Given this list of marker genes DEFB108B, ITPR3, UNC13D, RNASE3, H2BC17, ATP6V1B1, ATP6V0A1, CCT2, IGLV3-19, C1QA, CANT1, DOK3, SURF4, IGKV2-29, IRAK2, HEXB, SELL, ACTR2, CAPZA1, IGF2R, FOS, PRKCD, NHLRC3, PAK1, IRF3 (NCBI Gene Id 3661), SNAP29, LRRC14, TRIM25, LEAP2 (liver enriched antimicrobial peptide 2), CASP10 (caspase 10), IGKV2D-40, IGLV4-69, APEH, CLEC4A, GPR84, RAB3D, CST3, PLD3, HRNR, BTRC, PRG2, CALM3, TLR10, KIR2DS5, NCSTN, SPTAN1, S100A1, LAT, CFHR5, KRAS, CRK, CD177, USP18, ARHGAP9 (NCBI Gene Id 84526), DEFB125 (defensin beta 125), TEC, PSMA3, PRKDC, NFKBIA, ADAM8, IGHG1, BIRC2, RNF135, ADGRG3, ATP7A, CFHR1, GOLGA7, MIF, PIK3C3, DNAJC3, MAPK11, DSG1, ATP6V1B2 (NCBI Gene Id 526), MMP8, PRKCE, CHRNB4, ATP8B4, DEFB133, CLEC5A, F12, HSPA1B, FGL2, DEFB129, C5AR2, EPX, RAB31, CDA, MALT1, ARL8A, RAB18, AGPAT2, NLRC4, CYBA, KLRK1, IRAK1, MUC12, CFH, IFI16, TARM1, IGLC2, CD53, NOD2, ITLN1, DOCK2, FGB, IGHG4, VCL, FUCA1, LIMK1, IRAK4, PTPN4, IGKV3D-20, ARSA, SRP14, GNS, CD19, COMMD9, TNFAIP3, PSMB5, MUC16, PFKL, H2BC12, PDXK, DEFB112, DOCK1, PSMD2, SERPINB3, MYH9, IGLV2-14 (immunoglobulin lambda variable 2-14), TYROBP, SYNGR1, HRAS, DEFB123, ospC3, MYO5A, NOS1, ITGAV, DEFB1, TMEM63A, FCN3 (ficolin 3), RAB5C, MMP9, NOD1, RHOG, PLD2, RAB6A, IFNA1, DEGS1, DHX58, RIGI, DEFB130A, ATP6V0A2, DIAPH1, PPP2CB, SIGLEC16, UBE2L6, IGLC6, S100A8 (NCBI Gene Id 6279), IDH1, HSP70, MYO10, MASP2, TMC6, WIPF3, MAP3K7, PSMD11, ASAH1, CASP3, IGLC7, H2BC4, C6orf120, H2AC18, AZU1, DEFB108A, EPPIN (NCBI Gene Id 57155), POLR3H, TLR3, LTA4H, SLC2A5, NLRP3, H2BC3, ITGB2, MNDA (myeloid cell nuclear differentiation antigen), CSTB, SERPINB12 (NCBI Gene Id 89777), KNG1, IFNA16 (NCBI Gene Id 3449), TKFC, SSA2, YPEL5, PIGR, AHSG, PSMA7 (proteasome 20S subunit alpha 7), QPCT, VCP (valosin containing protein), IMPDH1, PRKCSH, BPIFB4, ERP44, UNC93B1, VAV3, C9 (complement component 9), PPP2R1B, H2AC6, CCT8, SHC1, MAN2B1, PPP3R1, CTSH, ITPR1, GM2A, LAMP1, POLR3B, IKBKE, CARD11, POLR3K, CD81, TRIM4, FCER1A, ABI1, CTSL, IGKV1D-12, IGLV, TNIP2, MYO1C, GRN, ENPP4, IGHV2-5, NCKIPSD, CASP8, S100A9, IGHV3-33, AGER, SERPINA3, NFAM1, DEFB128, IGLV2-11, IGLV3-1, CASP1, DEFB4A, LPCAT1, FADD, DEFB114, CAB39, OSTF1, DEFB121, CARD9 (caspase recruitment domain family member 9), PSAP, NBEAL2, ARPC4, IGHV4-59, COTL1, HSP90AB1, ILF2, TRAF2, HMGB1, MYD88, H3C15, XRCC5, SLPI, KLRC2, MAPK10, REG3G, DNM3, TLR5, IKBKG, MAPK3, TXN, SOCS1, 1C, IGHV3-9, CD59, TAB1, MEF2A, S100A7, CD180, CLEC4E, IGLV5-45, PADI2, PGM2, NPC2, RIPK1, COPB1, PSMD3, HK3 (NCBI Gene Id 3101), TAB2, IRF7 (NCBI Gene Id 3665), SYK, CTNNB1, NIT2, hly, ATP6V1G3, IGLV8-61, RAC1, DEFB103A, PGLYRP3, CFHR2, CALM1, NCF1, C8B, DEFB110, DHX9, MAVS, IGHV1-46, TOLLIP, TXNDC5, ARHGAP45, SERPINB10, CRISPLD2, porB, CFHR3, TBC1D10C, DEFB109B, N4BP1, PTPRN2, IGKV1-12, DEFA5 (NCBI Gene Id 1670), HLA-C, IMPDH2, IGKV2-30, MEF2C, RAB10, MME, VAPA, MANBA, ALOX5, STOM, IGHE, RIPK3, CCL22, RAB4B, PSMC6, IGKV1-33, VNN1, DEFA4, IFNA10, CD4, TXK, POLR3G, IFIH1, LRRFIP1, ANO6, HLA-H (major histocompatibility complex, class I, H (pseudogene)), SERPINB6, ARPC2, WASL, TMEM179B, CYFIP1, ATAD3B, BIRC3, B2M, TP53, IGHV3-53 (immunoglobulin heavy variable 3-53), SIGLEC9, RAB24, MEFV, TLR9, ARSB, MAP2K1, KIR2DS2, RASGRP4, CMTM6, NCF4, CLEC12A, S100P, CRCP, ATP6V1G1, F2, LCP2, MAPK1 (NCBI Gene Id 5594), MAPK7, VAV2, RBSN, SLC44A2, RAB7A, RELB, H2AZ1, FGG, TOMM70, PSMD8, CFD, H2BC5, SLC15A4, IGHV2-70, CD36, CHUK, ITGAM, KCMF1, PSEN1, IFNA8, HSPA1A, ATP6V1E2, PSMB6, IGLV2-8, C1S, USP14, SARS coronavirus, complete genome, CTSS, CTSC, NCR2, CFHR4, CEACAM3, ACP3, PRDX4, CXCR1, MASP1, ATP6V0D2, UBA3, PTAFR, IGKV1-16, MUCL1, CRACR2A, PSMA4, TXNIP, UBE2D1, UBR4, HBB, PSMA6, SIGLEC5, WASF1, IGLV1-51, PELI2, BCL2L1, ISG15, POLR3GL, ALAD, RNASET2, AHCYL1, LTF, LAT2, C4B, IFNA5, MUC6 (mucin 6, oligomeric mucus/gel-forming), KCNAB2, WAS, ORMDL3, ARPC1A (actin related protein 2/3 complex subunit 1A), RPS6KA2, SIGLEC15, CTSZ, 7a, IGLV2-23, KIR2DS4, MUC3A (mucin 3A, cell surface associated), PDPK1, MAP3K8, FLG2, CLEC6A, MS4A3, NLRP4, TRAPPC1 (trafficking protein particle complex subunit 1), LCN2, H4C1, WASF2, C5, ATP6V0D1, ADA2, FCER1G, CKAP4, BST1, IGLV5-37, NFKB1, TOM1, IGKV1D-16, PGLYRP1, H2BC14, IGLV3-25, SFTPA1, IGLV7-46, CASP2, VAV1, PSTPIP1, PIK3R4, YES1, CYB5R3, DSC1, SERPINB1, SLC11A1, UBE2K, LGMN, PIK3R1, UBE2V1, CCL17, TBK1, LRG1, IRF5, PECAM1, IKBIP, RAP1B, H2AB1, CAPZA2, ACTG1, ELK1, GYG1, RNASE6, SCAMP1, MPO, CTSB, HGSNAT, DEFB127, EEA1, C3, UBE2D3, POLR2L, H2BC21, SEM1 (NCBI Gene Id 7979), CEACAM8, BPI, CD58, TLR7, PSMA5, ATP8A1, DEFB135, APOB, GSDMD, RNASE2, RIPK2, POLR2F, ELMO2, TMT1A, DEFB116, RPS6KA1, SNAP25, C2, IGKV3-20, ATP6V0C, ALDH3B1, DGAT1, MAPK12, S, C7, UBE2D2, MUC3B, PKP1, FBXW11, LYZ, ITGAL, P2RX1, PLEKHO2, ATP6AP2, ATP6V1D, CD247, ACTR3, IGKV3-15, ABCA13, DDX41, COLEC11, ARG1, TRIM32, FCGR3B, NFKB2, TLR2, DNAJC13, PRSS3, IGKV1D-39, RPS6KA3 (NCBI Gene Id 6197), PPBP, CSNK2B, ATP6V1H, CLU, ACTR1B, LGALS3 (galectin 3), AIM2, DEFA6, DPP7, FCGR3A, MAP2K7, PSMC2, FYN, PSMC5, CASP9, FUCA2, DEFB104A, DEFA1 (NCBI Gene Id 504182), DEFB115, GBP4, NEU1, CD55, BIN2, IGHV4-34, IGHV1-69, GALNS, GRAP2, FGR, PANX1, AGL, IFNA14, GPI, PKM, PYGL, DNAJC5, CYLD, CPB2, RAB27A (RAB27A, member RAS oncogene family, NCBI Gene Id 5873), CCR2, C4A, C3AR1, ATG5, NFATC3, TMEM30A, IFNB1, KRT1, C1QB, DEFB134, PAK3, FRK (NCBI Gene Id 5752), FCGR1A, PYCARD, STK11IP, CLEC4C, DEFB124, CTSD, PSMD14, TIFA, CFP, TCIRG1, DHX36, WASF3, MYO9B, NLRC5, POLR3C (NCBI Gene Id 10623), OLFM4, CALM2, DYNLL1, HSPA6, APAF1, IGHG3, LAMTOR2, ICAM3, TSPAN14, CLEC10A, FRMPD3, SRC, NOS3, MAGT1, SARM1, DYNLT1, TLR1, CHI3L1, CTSG (cathepsin G), AOC1, ITK, CASP4, ITCH, GSN, DNASE1L1, AP1M1, IGKV4-1, BCL2, FPR2, CCR6, H2BC13, CDK13, PSMB4, CHGA, CEACAM1 (NCBI Gene Id 634), MLEC, SAA1, ATOX1, PTPRB, PSMD13, LAMTOR3, CRISP3, NCF2, CRP, HCK, IGLV4-60, FABP5, HSP90B1, CUL1, MAPK13, H2AC14, H2BC1, MUC19, CD93, NFATC1, 9b, TLR4, DTX4, GAB2, CAT, RAB44, PPP2R5D, MS4A2, POLR1C, BCL10, N, GBP2, PGLYRP2, REG3A, LY96, DEFB106A, fljB, DSP, IGKV1D-33, PI3 (peptidase inhibitor 3), IRAG2, PSMD7 (proteasome 26S subunit, non-ATPase 7), PA2G4, PPP2CA, MMTAG2, IGLV7-43, MUC20, PGM1, 3a, TIMP2, SERPING1, TRPM2, IGHG2, ZBP1 (NCBI Gene Id 81030), IFNA4, RPS6KA5, IGKV1-17, NFKBIB, RNF125, PELI1, ELMO1, SLC2A3, ARPC3, PRG3, IGLV1-47, CALML5, IGKV2D-30, ATP6V0B, SLC27A2, DUSP7, FOLR3, SNAP23, RAP2B, HRG, IGLV4-3, C8G, PLCG1, PLAUR, ADAM10, OTUD5, MYH2, CR1, POLR2H, PLAC8, PNP, TREX1, VAT1, RAP1A, APRT, TICAM2, UBA7, KIR2DS1, BPIFB1, CPNE3, ATP6V1A (NCBI Gene Id 523), MAP2K6, LCK, ITGAX, CD209, IGLV3-16, RASGRP2, H2AX, IST1, PLPP4, IGLV6-57, CYSTM1, PRTN3, WIPF1, DUSP4, CEP290, MAPK9, CD300LB, CPPED1, GZMM, LAIR1, HTN1, ATP6V1G2, PGRMC1, PIK3CB, ATP6V1F, APP, PPIE, PTPRC, IGKV1-5, GNLY, DEFB119, ALDOA, BRK1, CDC42, PSMC1, PTPN11, MAPK8, C5AR1, SLCO4C1, ATP6V1E1, TREM1, IGKV3-11, CNPY3, PAK2, BST2, C1QBP, PIN1, RAC2, ANPEP, NRAS, PSMA1, RETN, PYGB, JUP, GLIPR1, CXCR2, PLD4, mip, ADGRE5, CREG1, PPP3CA, MAP3K1, IGHV3-30, CTSV, IQGAP1, GUSB, A2M, BPIFA1, TASL, IGLV3-22, GHDC, H2AC7, PTK2, CREBBP, MUC21 (NCBI Gene Id 394263), ATP6V1C2, NDUFC2, TRAF3, IRAK3 (interleukin 1 receptor associated kinase 3), PRCP, ATP6V1C1, C1QC, DCD, CLEC4D, MAP3K14 (NCBI Gene Id 9020), CD44, B4GALT1, DDX3X, NCKAP1L, IGLV1-44, S100A12, TUBB, PPP3CB, PSMC4, DYNC1LI1, POLR3D, RAB14, FCN2, IGHV, RAP2C, PLPP5, POLR2K, CPN2, env, IGKV5-2, FPR1, ATP11A, QSOX1, ARPC1B, HERC5, IGLV10-54, ACAA1, C1R, DEFB126, GMFG, TNFRSF1B, GCA, IGHV1-2, IGHV4-39, POLR3A, PAFAH1B2, TAB3, BPIFB2, FTL, ROCK1, UBC, DSN1, CAPN1, PSMB1, CYBB, PLCG2, ABI2, VRK3, STING1, NFASC, HMOX1, NAPRT, VPS35L, XRCC6, PRDX6, IGHV3-23, DEFB130B, RELA, TICAM1, GGH, CD46, ORM2, PELI3, ARMC8 (armadillo repeat containing 8), GBP3, SKP1, CD3G, PSMB7, IQGAP2, C6, UBB, PTPRJ, IGKC, ABL1, CD33, ATP6V0A4, IGLV1-40, ATP6V0E2, ACLY, TANK, PLAU, TCN1, SERPINA1, C8A, MGST1, ATP6V0E1 (NCBI Gene Id 8992), HSPA8, LBP, DEFB107A, PDZD11, MBL2, ATG12, IGLV2-18, PDAP1, GDI2, SEMG1, IGLV3-27, TLR6, IFNA2, IGHV3-11, GAA, MUC13, LRRC7, LILRB2, NLRP1, IKBKB, TUBB4B, IGLV3-12, LAMP2, SVIP, FCAR, IFNA6, IGKV2-28, DEFA3, MAP2K3, RAB5B, ANXA2, S100A7A, DEFB132, NF2, DEFB118, GLB1, TNFAIP6, LILRB3, RNASE8, DYNC1H1, IGHV3-7, SIGLEC14, MUC4 (NCBI Gene Id 55804), TRIM21, S100A11, UBE2M, CAP1, PSMC3, IFNA13, IGLV3-21, H2BC12L, GRB2, OLR1, RHOF, PLA2G2A, RNF216, HLA-B, M, CLEC7A, GLA, H2BC9, HP, CPN1, PIK3R2, HMOX2, PSMD6, PRKACB, ATP11B, MRE11, PLD1, LY86, POLR3E, SIRPA, RHOA, CREB1, IL18, WIPF2 (WAS/WASL interacting protein family member 2), TMBIM1, IGKV2D-28, DBNL, ACTB, IGLC1, PRKACA, GBP1, DNM1, IGHV3-13, CTSK (NCBI Gene Id 1513), NFATC2, DNM2, SIKE1 (suppressor of IKBKE 1), DERA, FGA, MVP (NCBI Gene Id 9961), RASGRP1, ECSIT, NOS2, TTR, CD300A, STBD1 (NCBI Gene Id 8987), CFB, EEF1A1, KPNB1, PIK3CA, EEF2, MOSPD2, DEFB105A, LAMTOR1, CPNE1, MCEMP1, CD14, SOS1, ITPR2, CD63, CGAS, DDOST, IFNA17, COLEC10, PRKCQ, NME2, ADGRE3, HUWE1, LYN, ACTR10, OSCAR, IGHV7-81, HLA-E, DUSP6, KIR3DS1, ATF1, ATF2, MUC2, LPO, HSP90AA1, UBE2N, LILRA3, PTGES2, rep, IGHV3-48, ART1, MGAM, MUC7, fliC, IFNA21, PGLYRP4, ALPK1, NCK1, HPSE, CDC34, CTSA, MAP2K4, H3-3A, JUN, CYFIP2, MAPK14, P2RX7, PROS1, MUC15, ICAM2, ARPC5, H3C1, KLKB1, ADRM1, NCKAP1, IL1B, RNASE7, CFL1, FCGR2A, CEACAM6, HVCN1, NLRC3, RAF1, H2AC4, DEFB131A, RAB3A, COMMD3, AMPD3, CASP5, AP2A2, CR2 (complement C3d receptor 2), SIGIRR, EP300, OPTN, ATG7, DEFB117, MUC5B, TIRAP, MAPKAPK2, KLRD1, PSMB2, MUC5AC, VAMP8 (NCBI Gene Id 8673), DEFB113, HTN3, PSMA2, PPIA, H2BC11, SFTPD, DEFB136 (defensin beta 136), E, STAT6, CXCL1, PCBP2, POLR3F, PLA2G6, DUSP3, BPIFA2, BRI3, AGA, S100B, PSMD1, PSMD12 (proteasome 26S subunit, non-ATPase 12), RPS27A, CHIT1, UBA52 (ubiquitin A-52 residue ribosomal protein fusion product 1), CD47, POLR2E, CD300E, MMP25, C4BPA, VTN, NKIRAS2, RAB9B, H2BC15, PGAM1, ORM1, CD68, PSMB3, PTPN6, NLRX1, PRKACG, MUC17, GSTP1, C4BPB, CAMP, H2AC20, AAMP, FAF2, CAND1, RAB37, TLR8, MUC1, MAPKAPK3, IGLC3, IGLV2-33, SFTPA2 (surfactant protein A2), CNN2, BTK, POLR1D, NKIRAS1, TRIM56, PRSS2, prgJ, ALDOC, SUGT1, BAIAP2, IFNA7, STK10, TRAF6, ELANE, FTH1, CFI, GSDME, IGLV11-55, PPP2R1A, IGKV1-39, A1BG, TREM2, H2BC26, TAX1BP1, FCN1, PTX3, SDCBP, BPIFB6, HEBP2, IGLV1-36, SIRPB1, here is a description of the gene set: species: Homo sapiens part of: Immune System Innate immunity encompases the nonspecific part of immunity tha are part of an individual's natural biologic makeup Reactome Pathway: Innate Immune System